The following is a description of a gene set: Genes containing one or more binding sites for (NCOA4) in their promoter regions (TSS -1000,+100 bp) as identified by GTRD version 20.06 ChIP-seq harmonization. species: Homo sapiens from publication Yevshin I, Sharipov R, Kolmykov S, Kondrakhin Y, Kolpakov F (PMID 30445619) Human Gene Set: NCOA4_TARGET_GENES, and this is the list of marker genes: HECTD4, PET117, CSMD1, RPS6, CSNK1A1, ZNF202, H6PD, UBE2I, IRF9, ZNF672, INTS9, METTL18, LUC7L3, METTL25, DRG2, ATXN7L3B, GADD45B, POLDIP3, SRRM2, TNRC6C, DPH1, CDADC1, TAF4, PEX13, TMCO3, NR3C1, CSTF1, SNORD26, OGFOD2, BANP, ARID4A, ATF4, PRDX5, OR2L6P (NCBI Gene Id 81465), MYCBPAP, FAM13B-AS1, BRD10, PUS10, SNRNP48, GALK1, IER5, KLC2, AP4B1, PSMA3, ALDH5A1, ENSG00000187185, MGAT1, HADHA, RPL22, CDK13, TNFRSF4, ZNF837, AURKA, SIPA1, PYCR2, RUFY1, MIR130AHG, MIDN, ZFAND2B, MIR22HG, FIRRM, ILRUNP1, OSBPL8, TSPAN14-AS1, COX20, RAP1GAP, PHF5A (PHD finger protein 5A), NRDC, ATP6V0D1, UBE2B, FTL, SMC5, RNU5A-1, ANO10, SNORA57, SF3A3, CDK13-DT, HMGB2, FSCN1, TK2, NINJ2-AS1, TMEM184C, NDUFA3, LONP1, TRAF3IP3, CXXC5, GSEC, CACYBP, RSRC1, SNF8, CIB2, H1-3, VGLL3, FBXL5, CDC25B, PDLIM7, PI4KA, MTCYBP23, RTCA-AS1, HPS1, RPSAP13, ZNF19, UBE2D3, RILP, SGIP1, DCTN6-DT, LRBA, RIOK3P1, ZNF169, WFDC2, JUNB, ABCA7, LINC01089, HDAC4, DNAJC7, SAE1 (NCBI Gene Id 51502), ELP4, PHYHD1, MIR4638, HEXA, MADD, NDUFA6, SDCBP, SLC20A1-DT, DNAJB2, POLR2C, CRTC1, GSTT4, PHF12, SIKE1, ACOT12, PPP2R5A, IKZF4, MT-CO3, THOP1, SRPK1, YAF2, METTL14, CNPPD1, PRADC1, LZTR1, PITPNM1, OGG1, JRK, GLUL, CDIPTOSP, PRORP, URB2, PINK1, RNU12, TRMT112, STK4-DT, ID2, ATP6V0D1-DT, KAT14, USP7, TBC1D10A, EEF1AKMT2, PEA15, C12orf57, UCP2, ASNSD1, SPTB, TRPM2, POMT1, PARP1, TRIB3, TUBA1C, SH3BP2, RNU4ATAC, UQCC3, VPS37C, LSM8, GAB1, ANXA2R, TAF10, ERO1B, JADE1, BSG-AS1, PLEKHG2, ZCWPW1, NDUFA6-DT, RCN1P2, ZNF580, PDE4A, MRPS23, ZC3H6, TAOK3, HDGF, PRKCH, PEF1, RPS2P1, GINS3, CCDC30, NIPAL3, RNA5SP218, MIR320C1, ZNF394, HADHB, NOP14-AS1, TJP1, MIA2-AS1, GOLGA2P11, H2AC20, ATG101, RPA1, GNE, TOMM22, DSP, HMGB1, WEE1, EBF1, ATP2B4, CIRBP, CD209, SLC41A1, NRL, MT-TR, SLC38A9, H2BC11, H4C1, BBOF1, RNA5SP106, VPS39, STOM, USB1, PCID2, ZDHHC12, SLC35A5, GANC, XBP1, RABGGTA, ZNF787, CCDC59, PRKAG1, SLC44A1, UBE2J2, HMGA1, FNBP4, LARP7, APOBEC3G, H1-10-AS1, RNU11, WIZ, MIF4GD-DT, POLR2D, PPP2R3C, PEX1, RPS15A, PLEKHA2, MARS1, EIF3D, KLF6, PPP5D1P, CDKN2AIPNL, DVL3, THRA, FBXL15, HDAC11, DYRK1A, VPS13D, COL19A1, TDH-AS1, PPIL4, POFUT1, PTCD1, ACACB, MIR4515, SEPHS1, CFAP184, TIMM10, HMGXB4, CNBD1, SRRM2-AS1, MTHFSD, ZNF432, STPG1, MT-ND4L, ZNF234, ARHGEF16, BOLA1, PLA2G6, SNORD54, CHASERR, ROM1, RPL18, IRGC, CHST12, RAF1, FAM13B, ANXA2, ZC3H4 (zinc finger CCCH-type containing 4), PIGBOS1, EHMT1, OTUB1, ESCO2, FES, PLB1, FOXP2, FZD1, C15orf39, RNVU1-26, SPATA2, FCHSD2 (NCBI Gene Id 9873), SF1-DT, OSBPL2, UBAP2L, TNFRSF14-AS1, POC1B, METTL8, WDR19, RNVU1-19, SRRM1, CALM1, LRP12, SLC2A1-DT, ADGRL1-AS1, AREL1, TMEM151A, CRKL, LRFN3, GLIPR2, GUSBP5, DUSP22, PSCA, HNRNPLL, RPS15, MRPS15, SH2B1, SIDT2, H4C16, ZMIZ2, TMEM138, MELTF, XPO5, TRMT12, LINC01431, DNAJC22, RPS9, HDDC3, SLC38A10, DNAH8-AS1, VPS13B, CDC7, ZNF148, PPP4R3A, RNVU1-7, JAZF1, HEXIM2, RNU7-1, USP35 (NCBI Gene Id 57558), LINC01264, JUN-DT, ISY1, MYL6B-AS1, LBHD1, VPS35, ACOT7, LINC02659, MEF2D, FBXL17, SNORA50C, MIR3188, PCIF1, RNF26, HOOK2, TRIM11, CFAP61, ING3, LINC01703, FXN, EZH2, PAXBP1, AHNAK2, ZNF319, SRSF11, KDM8, DNM1L, ATG2A, WARS1, MLH1, KLHL22, BLTP1, MRPL12 (mitochondrial ribosomal protein L12), SIAH2, SECISBP2, PIP5K1B, ZNF606-AS1, TNKS2, RBM12B, USP24, CPSF4, TMEM8B, USP31, HBB, LIPA, GTPBP10, ZNF131, RAD9A, SNHG7, MYO5A, SCYL2, NXF1, DCLRE1B, KDM5B, PRICKLE4, ST6GALNAC6, TKT, GSDMD, KLF1, CLUL1, DTNA, PCGF3, TDH, FBXW5 (NCBI Gene Id 54461), UQCC4, TBC1D14, RNU6-1177P, GTF2H4, SSBP4, SCAF11, ARHGEF37, CC2D1B, C2CD5, DPM2, C3orf86P, P3H2, PHLPP2, MIR4727, KPNA1, UROS, RIMBP3, ACCS, FAN1, GMPR, CASP4, PISD, SLBP, TAF5, CREB3, PSMA1, FOXP1, SERTAD3-AS1, MPHOSPH9, H3-3B, INPPL1, MADCAM1 (mucosal vascular addressin cell adhesion molecule 1), SNORD43, BRD3OS, MHENCR, NCBP3, CFAP20, VPS13B-DT, GATC, GEMIN6, CHMP3, KIAA0753, EPM2AIP1, POLE, RWDD1, NOP56, POLE3, RRAGC-DT, MTND6P4, MLST8, NCOR2 (nuclear receptor corepressor 2, NCBI Gene Id 9612), ZNF142, ZC3H15, SFXN5, IMMP1L, RAB23, RPS14, CCNA2, MON1B, RAPGEF4-AS1, KDM1A, PEX16 (NCBI Gene Id 9409), PPP4R3B, POC1B-GALNT4, TXN, NACC1, ARIH2, EPCIP-AS1, LAMTOR1, GMFB, THAP9-AS1, ZBED4, NFX1, DGKA, ATXN7L1, H2BC9, ZNF207, STK35, EML3, SORBS1, ENSG00000199196, NHERF1, CCDC18, ENSG00000268129, CDIPT, ZBTB45, TEX2, AHR, MIR5188 (microRNA 5188), CSKMT, CDC25C, ZNF767P (zinc finger family member 767, pseudogene), OR51I2, NPAS4, TMC6, SCN1A-AS1, CD70, NSMCE1, STK4, EGR1, PSMD3, KLHDC10, GPR137, AGAP3, SAMHD1, SNX14, RANBP9, METTL14-DT, MYL6, POLA1, TTC23L-AS1, DOCK6, USP25, COPS9, UBE2Z, BCS1L, KPNA6, CNNM3, SLC4A1, ANKS4B, INO80, MT-TC, PIGO-AS1, DNAJB4, ERLIN2, RRP12 (ribosomal RNA processing 12 homolog), FAM114A1, PSMA3-AS1, ZDHHC7, MT-RNR1, DNAI4, NLRX1, COPS4, PLAGL2, DYNLL2-DT, ADPRS, CD46, ARL14EP, SRRM3, EXOC8, SIX1, IGFLR1, RPS20, RFESD, C10orf143 (chromosome 10 open reading frame 143), PRDX1, UNC79, ENSG00000249341, FCF1, TUT4, VPS28, MRPS31P2, DDX46, RBM22, PLA2G15, SEC11A, MAP4K2, ACBD6, SEH1L, YIPF1, KCMF1, SERTAD3, TRIAP1, SECTM1, CKLF-CMTM1, PCBP1, PCBP2, RBM28, DRAM1, LINC01719, C17orf75, CLP1, COX5B, PXN-AS1, MIB2, BCAS4, LINC01298, H1-5, SEC14L1, PRPF18, ADGRG7 (adhesion G protein-coupled receptor G7), CHKA, SUSD1, ALKBH1, ANKRD29, KRTAP4-1, PSD, TRAPPC4, OGFOD3, GFI1, RELA, VPS52, RPS4X, LGALS12, H1-10, CUL4A (NCBI Gene Id 8451), HDAC4-AS1, ARHGAP44-AS1, SDE2, ZDHHC24, EXOSC9 (NCBI Gene Id 5393), SLC3A2, RPS12, GFAP, TSACC, PPM1F-AS1, MT-TP, SMARCD1, RIF1, PNPLA6, FANCD2, TP53INP1, SLC25A42, TBC1D10B, PPP3CA, ATG3, TMEM167B (NCBI Gene Id 56900), C17orf99, ATP5F1D, CIDECP1, CATSPERD, PLEKHG1 (NCBI Gene Id 57480), CERNA3, RPL3, SAXO5, CCDC69, C11orf71, RPL10, APH1A, SWSAP1, MAN1A1, RTCA, TTC38, WASL, RPL27A, THUMPD3P1, RPL7L1, DNMT1, DLST, SEC31A, CCDC106, TMEM87B, VAMP4, STAT1, BBC3, UBFD1, ARL6IP4, NDUFB7, RAB27A, HSPA2-AS1, IDH3A, DCTN5, RHBDL1, TMED5, BROX, RPLP0, TCAF1, PIP4K2B, PRPSAP1, CHPT1 (choline phosphotransferase 1), TMEM41B, FRY, CKLF, ELP2, NDUFA5, TCEA1, HEXA-AS1, RPS18, ZNF274, PTPN2P2, HEXD, JUND, RN7SKP247, MT-TA, TNPO2, CBLL1, RHBDF1, DPP3, FGL1 (NCBI Gene Id 94993, fibrinogen like 1), LINC02202, AKT2, LINC01126, ZNF606, ILK, SPRTN, MCU, PALM3, XPO1, LCN9, ACE, NDC1, COL8A2, ARL15, DCDC1, ASCC3, SNX18, ARMH4, STT3B, TUBA4A, ERN1, TUBB4BP5, TRAPPC10, C11orf98, EARS2, C19orf67, PAK4, EIF4A2, DCTN6, GJB7, ATP5MC2, SLTM, H2AC21, DENND4B, DPP3-DT, PRC1, IRF2BP1, COX7A2 (cytochrome c oxidase subunit 7A2), PTPN11, ZNHIT3 (NCBI Gene Id 9326), PYM1, MIPEP, IL2RB, SNRPA1-DT, MT-TF, ALB, ZNF251, MTCO3P12, WDR25, LINC02290, SPHK2 (NCBI Gene Id 56848), EFHB (EF-hand domain family member B), UBE2T, SAXO3, CARF, MEPCE, RETREG2, UBE2G2, MAP3K11, CPPED1 (NCBI Gene Id 55313), MIF4GD, RPL35AP36, KIFC3, MAST3, MT-ATP6, ZNF518A, GTF2A1-AS1, CHRAC1, SNHG17 (NCBI Gene Id 648273), ZBTB11 (zinc finger and BTB domain containing 11), GCNT1, AKAP9, PKN2 (NCBI Gene Id 5586), SNRPC, DEPDC5, GTF2A1, SNORD104, SNORD101, EXOC2, TBPL1, CNOT4, PEX14, LNCRNA-IUR, PDCD2L, RUNX1T1, MPPE1, MT-TN, RCN2, TIFAB, RAD54L, PCNX3 (NCBI Gene Id 84183), SRSF6, UQCC2, SLC39A6, TRA2B, ERCC1, NDUFB1, MFSD10, SRXN1, TOR1AIP1, ATP8B3, RPS25, ENSG00000267248, SYCP2, TAF5L, CLASP1, CYLD, RHOF, USP21, MT-ND4, TAF1D, SNORD25, C8G, TMEM167B-DT, RNU6-430P, ZNF516, H2AZ1, RPL36, EIF3H, ID2-AS1, CTDSP1, SNORD27, CALY, CFAP77, CPEB3, HPN, MROH6, PPIAP34, NUMA1, PSMC6, PHTF1, TFRC, EIF4EBP2P1, TLN1, SIAE, KIAA0232, SCAMP4, SLC14A1, PALB2, SNAP29, FUT6, ZDHHC12-DT, LLPH-DT, SNHG1 (small nucleolar RNA host gene 1), PI16, TAF3, MYCBP, SMARCC2, JOSD1, DVL2, MRPL9, SH3D19, DISC1FP1, WSB1, ZCCHC4, RPL26, TRMT1, ABCB6, RNU5E-6P, MED13L, CIPC, NPW, ENSG00000260316, RBSN, MYB, DET1, BTBD7, ZNF598, VEGFC, UBC, MARK4, BICD1 (BICD cargo adaptor 1), CHKA-DT (CHKA divergent transcript), HSF4, PTPN12, ENSG00000227218, PABPC1, RPL15, H2BC5, CRYZL1, LINC01387, RNVU1-30, KMT2E, MIR3181, SLC22A16 (NCBI Gene Id 85413), MRPL53, CTNND1, KRTAP1-1, G3BP1, SNRPB2, CDC42BPG, RPL9P14, SKAP2, CEP131, CCDC159, RN7SL83P, ARID3A, SCYL3, DCUN1D2, SNHG25, CLPTM1, SNRPA1, NUP153, TFIP11, RPS7, TUBB4B, C9orf43, CALM3, TSPOAP1, FMN2, H3C12, CDKL3, NKIRAS1, ACTB, SLC4A2, TM4SF19-AS1, BSG, CWC25, DLGAP1-AS2, YPEL4, U2SURP, CREB1, ASAP1, MYRFL, DRAM2, RCOR1, ORC6, HES6, LLPH, ATP13A3, PCBP1-AS1, USPL1 (NCBI Gene Id 10208), MIR320D1, ENSG00000283078 (novel transcript), SUMO3, NMT2, TSGA10, RBM48, AUP1, BTBD1, ADAT3, SOS1 (SOS Ras/Rac guanine nucleotide exchange factor 1), RRP8, NUP42, ODF2L, CACTIN, SHFL, EIF2B3, C19orf48P, YARS1, SF1, DNAJB6, RBM25, SNORD118, SPOCD1, S100PBP, MIR4522, ACTN3, SMG1, SLC2A1, WDR81, DEPDC4, PLS3, H2AZ1-DT, SRSF7, CYLD-AS1, SRSF3, CITED2, SPPL2A, LACTB, DPY19L4, NRGN-AS1, LINC00963, SNORD13, CEPT1, RNU6-603P, COPS5, MBD1, SLC1A5, BCCIP, TMEM87A, ABCB9, COX16, RSRP1, TNKS2-DT, HEXIM2-AS1, MAEA, HEXIM1, KMT5C, TRIM25, H2AC11, EHBP1, CNTN3, KLF15, UBB, NFE2, FBXL3, HEATR5A, FAH, TPRN, CSPP1, CBLL1-AS1, RAD51, SLFN13, VWA7, TIGD1, CCNL1, H2BC21, AGFG2, NKAPL, AIDA, ABHD5, MTRFR, TOMM22-DT, TMEM184C-DT, PRKAR2A, TSPOAP1-AS1, TNFRSF14, MUCL1, ZBTB4, AMBRA1, ZNF280D, AP5S1, ARAP1, LIPT1, NFYB, MIR6853, SLC9A1, DNAH7, RPL8, MKNK2, RBFOX3, GMEB2, HNRNPH1, KLHDC3, CCT7, ANKRD44, CFL1, KRAS, GCHFR, CHD9NB, MLLT6, PUF60, TRIM41, PPP2R5B, VPS37D, RPL28, LAMP1, PABPC4, MDM1, LRRC47, MYLIP, RPL41, MTND5P11, BZW2, SLC35F5, DYNLT4 (dynein light chain Tctex-type 4), ACO2, C11orf24, PRDX2, DBP, NIBAN2 (NCBI Gene Id 64855), MYO1D, SLC12A9, ASF1B, ATP13A3-DT, SPTLC1, PSMD8, KXD1, EEF2, LARP1, TROAP, ARHGEF1, MRPS33, ST3GAL4, DERL1, HEATR5A-DT, MAGT1, NFIA, NEAT1, EHD1, DCUN1D5, MADD-AS1, RNASEH2A, SLC6A1-AS1, TCF12, MT-TY, BUB1B, CSNK2A1, TTI2, TTLL5, MYZAP, RNU6-1242P (NCBI Gene Id 106480108), NFATC3, CCNB2, SRPRB, LDLRAP1, COX19 (cytochrome c oxidase assembly factor COX19, NCBI Gene Id 90639), PPP1R12B, HIF1AN, H4C2, LASP1, NNT, PGPEP1, POLR2A